Given this list of marker genes Chst7, Chst12, Chst13, Chst3, Ust, Chst11, here is a description of the gene set: studied in species Mus musculus Mouse Gene Set: GOMF_CHONDROITIN_SULFOTRANSFERASE_ACTIVITY Catalysis of the reaction: 3'-phosphoadenosine 5'-phosphosulfate + chondroitin = adenosine 3',5'-bisphosphate + chondroitin sulfate.